Given this list of marker genes JADE3, SULF1, FCGR1A, ELAC1, NUAK2, PIM2, ZFPM2, CPD, KLK4, NR2C2, METTL4, C4orf46, PHC3, IQSEC1, OTUB2, CHAMP1, NKX3-1, KCNIP2, NPAS4, FLT1, PTGES3, ATXN7L3B, GPR156, AGK, CCNI2, RAB10, NCAPG, PROK2, UHRF1, RAN, ZNF124, PLCXD2, CREBRF, TSPAN17, WDR64, RNF168, RPN2, AK7, NHSL3, VPS53, here is a description of the gene set: Genes predicted to be targets of miRBase v22 microRNA hsa-miR-422a in miRDB v6.0 with MirTarget v4 prediction scores > 80 (high confidence targets). from publication Chen Y, Wang X (PMID 31504780) Human Gene Set: MIR422A studied in species Homo sapiens